The following is a description of a gene set: studied in species Homo sapiens The directed movement of organic anions into, out of or within a cell, or between cells, by means of some agent such as a transporter or pore. Organic anions are atoms or small molecules with a negative charge which contain carbon in covalent linkage. Human Gene Set: GOBP_ORGANIC_ANION_TRANSPORT, and this is the list of marker genes: PLA2G3, SLC6A12, SLC37A1 (solute carrier family 37 member 1), DRD3, P2RX7, SLC39A14, ABCC3, RBP7, SLC38A2, BEST1, PPARA, PLA2G12B (NCBI Gene Id 84647), SLC13A3, SLC25A17, PLEKHA8P1, SLC16A6, CPTP, OC90, SLC22A25, LRRC8D, PLA2G2F, GRM1, ABAT, SHOC2, RPS6KB1, SLC25A4, SLC16A3, SLCO1B3, SLC35B3, ACSL3, SYT4, GABBR1, IRS2, SLC26A7, PSEN1, SLC25A16 (solute carrier family 25 member 16), SLC7A11, SLC51B, RGS4, SLC38A11, SLC6A14, SLC25A2, ARL6IP1, EPM2A, P2RX4, PLA2G4F, SLC25A44, SLC16A13 (solute carrier family 16 member 13), SLC7A5P1, PRAF2, ATP8B1 (NCBI Gene Id 5205), AKR1C4, LRP2, G6PC1, SYK, SLC25A31, SLC2A1, SLC5A8, GLTPD2, SLC4A2, CLDN2, AVPR1B, UCP2, STXBP1, PLA2G4A, PLA2R1, FABP1, SLC25A18, EMB (embigin), SLC37A2, SLC5A6, SLC1A3, THBS1, SLC26A3, SLCO2A1, PDPN, CYP4A11, SLC32A1, SLC22A24, LYPLA1, SLC4A3, SLC26A5 (NCBI Gene Id 80269), SLC27A1, SLC39A4 (solute carrier family 39 member 4), CES1, NMB, SLC26A8, EPRS1, SLC4A7, SLC7A2, SLC38A5, PLA2G2E, PLA2G1B, LRRC8C, NTRK2, SLC17A5, SLC3A2, SLC13A2, SLC16A7, SLC15A4, SFXN2, PTGS2, SLC4A10, PROCA1, SLC25A25, SLC12A2, SLC27A3, SLC38A8, SLC10A3, SLC22A11, FABP4, UMOD, SLC17A4, SFXN1, SLC2A11, SLC2A5, SLC25A47, SLC6A15, SLC22A12, CLN3, SLC16A4 (solute carrier family 16 member 4), KCNJ8, UGT1A3, SLC35D2, CPT1B, SLC35B2, ATP1A2, ABCD3, SLC52A1, KMO, TTYH2, PLEKHA8, SLC23A1, PLA2G2C, CASR, SFXN3, AGXT (alanine--glyoxylate aminotransferase), TRPC4, SLC19A1, CTNS, VPS54, SLC22A2, FABP3, CFTR (CF transmembrane conductance regulator), PSAP, ACSL4, SLC22A3, SLC35B1, MFSD10, SLC3A1, SLC25A24, CYB5RL, ARL6IP5, ADORA2A, SLC6A7, SLC36A3, RTBDN, OXT, ABCC10, SLC25A10, SLCO4A1, SEPTIN2, CYP7A1, LYN, SLC26A9, PER2, SLC47A1, PLA2G2D, KCNK2 (NCBI Gene Id 3776), SLCO4C1, SLC25A21, PLA2G10, SLC2A2, SLC38A9, ADCY10 (adenylate cyclase 10), SLC26A11, MIR33A, IL1B, GOT2, SLC4A8, PRKG1, SLC4A1, SLC22A8, SLC27A5, SLCO1C1 (NCBI Gene Id 53919), SLC35A3, CLTRN, SLC35A1, SLCO1B3-SLCO1B7, SNCA, ABCC5, G6PC3, SLC2A10, SLC10A2, SLC2A7, TRH, SLC2A3, ABCB11, SLC7A14, CYB5R4, AVPR1A, SLC38A10, AKR1C1, SLC39A6, MTTP, LRRC8B, TTYH1, SLC25A29, ANXA1, SLC25A19, ABCC6, SLC35C2, SLC22A14, CPT1A, AKT1, ABCD4, SLC7A5, SLC25A23, SLC26A6, SLC6A8, ABCB1, PLA2G5, SLC25A42, SLC17A8, SLC25A13, ASIC3, SLC66A1LP, SLCO1A2, SLC44A4, SLCO6A1, SLC16A1, SLC2A9, DRD4, SFXN5, PNPLA8, SLC10A5, SLC2A6, SLC16A11, NHERF1, CALHM2, EDN1, ABCD1, CROT, ABCC4, ACSL5, SLC26A4, SLC16A14, NPY5R (NCBI Gene Id 4889), SLC6A17, BEST2, ADORA1, NFE2L1, CEACAM1, APBA1, SLC25A6, SLC7A5P2, SLC10A1, SLCO2B1, PIANP, SLC1A1, SLC38A6, SLC37A4, SLC16A5, SLC4A4, CRABP1, SLCO1B1, SLC46A2, SLC25A39, SLC39A8, CD47, SLC13A5, CERT1, SERINC3 (NCBI Gene Id 10955), SLC6A6, GJA1, SLC7A9, SLC43A3, SLC7A1, TNFSF11, SLC1A5, AKT2, ABCC2, NOS2, RBP2, SLC22A13, TMEM135, SLCO1B7, SLC25A5, PLA2G2A, SLC43A1, GNAT2, FABP5, SLC26A1, FABP5P3, FOLR1, GFAP, FABP12 (fatty acid binding protein 12), LRRC8E, LLGL2, SELENON, SLC7A6, SLC25A12, GLTP, ABCC1, SLC52A3, SLC33A1, SLC39A10, SLC6A20, SLC38A3, SLC4A11, SLC1A2, NR0B2, FABP2, PMP2, SERINC5, SLC6A9, SLC17A6, PLIN2, ANKH, PPARG, CACNB4, FABP9, FOLR2, SLC16A12, FABP6, SLC6A11, SLC26A10P, NMUR2, SLC6A1, ABCG2, SLC4A5, SLC22A1, LEP, CALHM4, PLA2G12A, SLC43A2, FIS1, SLC22A7, SLC17A3, CALHM5, PTGES, ACE, REPIN1, GIPC1, GRM2, CALHM3, SLC66A1, RBP5, RAB3GAP1, SLC22A9, BDKRB2, BEST4, LRRC8A, SLC17A2, MPC1, SLC1A4, SLC1A6, SLC11A1, SLC26A2, CPT2, GRM7, SLC36A2, ERFE, SLC17A1, SLC2A4, APOE, FOLR3, ABCC11, SLC39A5, SLC25A22, TSPO2, SLC16A8 (NCBI Gene Id 23539), SLC22A20P, CD36, SLC38A7, KCNJ10, SLC25A41, DRD2 (NCBI Gene Id 91906), SLC2A14, SLC16A9, SLC2A8, MIF, DTNBP1, RHAG, SLC27A6, KCNK1, SLC35D1, SLC36A4, SLC7A10, SLC17A9, SLC36A1, ABCB4, MPC2, TMEM241, SPX, RBP1, SLC35B4, MGST1, SLC25A40, SLC6A13, FABP7, SLC27A2, MPC1L, SLC25A26, SLC25A15, CRABP2, CALHM6, SLC35D3, SLC39A12, SLCO5A1, SLC10A6, PANX1, AVP, SLC27A4, SLC16A2, CYB5R2, SLC25A32, TTYH3, SLC52A2, TNF, CALHM1, SLC19A2, RGS2, MFSD2A, SLC16A10, SLC51A, SLC46A1, SLCO3A1, CR1, SLC35A2, SLC7A7, PPARD, ABCD2, CLN8, TNFRSF11A, SLC7A3, SLC7A8, CYB5R1, SLC10A4, SLC22A10, ABCC8, CYP4F2, SLC5A12, SLC22A6, SLC6A5, SLC17A7, ACE2, SLC38A1, SLC4A9, ITGB1, ACACB, NTSR1, SLC7A13, SLC25A11 (NCBI Gene Id 8402), SLC38A4, MFSD12, SLC1A7, NF1, ACSL1, SLC25A38, SLC25A20, SLC37A3, SLC25A1, NR1H4, CA4, SLC23A2, FGF19